Given this list of marker genes TREX1, DNAAF3, KCNJ11, ATM, KCNJ8, INPP5D (NCBI Gene Id 653796), KL, MSH2, SCN1A, SOD1, COQ7, WRN, PRDM2, LEP, RAD54B, TP53, LRRK2, GHRHR, ERCC2, ATP8A2, CGAS, RAD54L, SIRT6, MSH6, MFSD8, B4GALNT1, SUV39H1, ATN1, SGSH, TP63, ERCC1, TFCP2L1, NAGLU, LIPA, GBA1, ZMPSTE24, LARGE1, BBC3, here is a description of the gene set: Human Gene Set: GOBP_DETERMINATION_OF_ADULT_LIFESPAN studied in species Homo sapiens The pathways that regulate the duration of the adult phase of the life-cycle of an animal.